The following is a description of a gene set: Gluconeogenesis. Pathway ID: N01605. Pathway type: Reference. Pathway class: nt06031 Citrate cycle and pyruvate metabolism. Pathway Definition from KEGG: Pyruvate -- PC -> OA -- MDH1/2 >> PCK1/2 -> PEP species: Homo sapiens Human Gene Set: KEGG_MEDICUS_REFERENCE_GLUCONEOGENESIS, and this is the list of marker genes: PCK1, PC, MDH1, PCK2, MDH2